The following is a description of a gene set: studied in species Homo sapiens Human Gene Set: WALLACE_PROSTATE_CANCER_UP Genes up-regulated in prostate tumor vs normal tissue samples. from publication Wallace TA, Prueitt RL, Yi M, Howe TM, Gillespie JW, Yfantis HG, Stephens RM, Caporaso NE, Loffredo CA, Ambs S (PMID 18245496) The incidence and mortality rates of prostate cancer are significantly higher in African-American men when compared with European-American men. We tested the hypothesis that differences in tumor biology contribute to this survival health disparity. Using microarray technology, we obtained gene expression profiles of primary prostate tumors resected from 33 African-American and 36 European-American patients. These tumors were matched on clinical variables. We also evaluated 18 nontumor prostate tissues from seven African-American and 11 European-American patients. The resulting datasets were analyzed for expression differences on the gene and pathway level comparing African-American with European-American patients. Our analysis revealed a significant number of genes, e.g., 162 transcripts at a false-discovery rate of <or=5% to be differently expressed between African-American and European-American patients. Using a disease association analysis, we identified a common relationship of these transcripts with autoimmunity and inflammation. These findings were corroborated on the pathway level with numerous differently expressed genes clustering in immune response, stress response, cytokine signaling, and chemotaxis pathways. Several known metastasis-promoting genes, including autocrine mobility factor receptor, chemokine (C-X-C motif) receptor 4, and matrix metalloproteinase 9, were more highly expressed in tumors from African-Americans than European-Americans. Furthermore, a two-gene tumor signature that accurately differentiated between African-American and European-American patients was identified. This finding was confirmed in a blinded analysis of a second sample set. In conclusion, the gene expression profiles of prostate tumors indicate prominent differences in tumor immunobiology between African-American and European-American men. The profiles portray the existence of a distinct tumor microenvironment in these two patient groups., and this is the list of marker genes: PPP3CA, AHCY, HPN, MYC, ST14, POLD2, DAP (death associated protein), SLC25A6, AMACR, PRSS8, LIG3, EIF3I, UAP1, FASN, ODC1, GFUS, SOX4, GDF15, TPD52, BDH1